The following is a description of a gene set: The gene expression profile of the aging process was analyzed in skeletal muscle of mice. Use of high-density oligonucleotide arrays representing genes revealed that aging resulted in a differential gene expression pattern indicative of a marked stress response and lower expression of metabolic and biosynthetic genes. Most alterations were either completely or partially prevented by caloric restriction, the only intervention known to retard aging in mammals. Transcriptional patterns of calorie-restricted animals suggest that caloric restriction retards the aging process by causing a metabolic shift toward increased protein turnover and decreased macromolecular damage. Downregulated in the gastrocnemius muscle of aged adult mice (30-month) vs young adult (5-month) from publication Lee CK, Klopp RG, Weindruch R, Prolla TA (PMID 10464095) Mouse Gene Set: LEE_AGING_MUSCLE_DN species: Mus musculus, and this is the list of marker genes: Abcb4, Dbp (NCBI Gene Id 13170), Pola2, Ndn, Nr2f1, Tnfrsf4, Rai2, Wnt4, Phox2a, Prkcsh, Ppp3cc, Zfp637, Sin3a, Pla2g7, Calm3, Psmc3, Adam28, Psmb8, Hspa8, Myh2, Eef1g (eukaryotic translation elongation factor 1 gamma), Col1a2, Ptprr, Usp50, Tst, Pmp22, Cdk11b (cyclin dependent kinase 11B), Zfp97, Apbb2, Fdft1, Usp4, Ppp1r2, S100a10, Bmp8b, Col3a1, Col1a1, Lonp1, Il6st, Pex2, Gfer, Cltb